The following is a description of a gene set: from publication Marigo I, Bosio E, Solito S, Mesa C, Fernandez A, Dolcetti L, Ugel S, Sonda N, Bicciato S, Falisi E, Calabrese F, Basso G, Zanovello P, Cozzi E, Mandruzzato S, Bronte V (PMID 20605485) Human Gene Set: GSE21927_BALBC_VS_C57BL6_MONOCYTE_SPLEEN_DN Tumor growth is associated with a profound alteration of myelopoiesis, leading to recruitment of immunosuppressive cells known as myeloid-derived suppressor cells (MDSCs). Analyzing the cytokines affecting myelo-monocytic differentiation produced by various experimental tumors, we found that GM-CSF, G-CSF, and IL-6 allowed a rapid generation of MDSCs from precursors present in mouse and human bone marrow (BM). BM-MDSCs induced by GM-CSF+IL-6 possessed the highest tolerogenic activity, as revealed by the ability to impair the priming of IFN- -producing CD8+ T cells upon in vivo adoptive transfer. Moreover, adoptive transfer of syngeneic, GM-CSF+IL-6-conditioned MDSCs to diabetic mice transplanted with allogeneic pancreatic islets resulted in long term acceptance of the allograft and correction of the diabetic status. Cytokines inducing MDSCs acted on a common molecular pathway. Immunoregulatory activity of both tumor-induced and BM-derived MDSCs was entirely dependent on C/EBP transcription factor, a key component of the emergency myelopoiesis triggered by stress and inflammation. Adoptive transfer of tumor antigen-specific CD8+ T lymphocytes resulted in therapy of established tumors only in mice lacking C/EBP in myeloid compartment. These data unveil another link between inflammation and cancer and identify a novel molecular target to control tumor-induced immune suppression. We used gene expression analysis to identify those factors, secreted by tumor-infiltrating MDSC, which could drive emathopoiesis. Moreover we compare gene expression profile of tumor-induced MDSC, obtained from either the spleen and the tumor infiltrate of tumor bearing mice, and in vitro bone marrow-derived MDSC. species: Homo sapiens Genes down-regulated in spleen CD11b cells: BALBc versus C57BL6 mouse strains., and this is the list of marker genes: ITPKB, NDUFAF1, SWSAP1 (NCBI Gene Id 126074), GARIN3, SLC25A45, VWDE, LACTB, DUS4L, IRAK2, ZNF407-AS1, ERCC5, LINC01554, LRRC2, LGI2, ZNF85, RTL8C (NCBI Gene Id 8933), LAMB2P1, KRT222, RTKN2, SLC24A5, GAPDHP62, AGPAT1, TPRG1, STX12, MESD, FAM169A, NQO2, DNAL4, SRGAP2, PXYLP1, PLXNA1, NUP37, CHI3L2, FKBP1B, F8, GALNT11, SLC40A1, CSNK1G1, ANKRD40, ZNF750, FAM220A, NFE4, TRBV27, BBS12, LYSMD3, SNX10, PRUNE1, LMAN1, NNMT, ANKRD36, XPNPEP3, TARS3, KRCC1, BLOC1S5, TTC27, YIPF5, BTBD8, CR1, LRRC14, SHBG, CCDC162P, SNHG12, GOLGA2P5, DOCK8-AS1, ARHGAP45, SLC35E1, DHX36, UMPS, ZNF786, ANKRD23, EPHA5, HIVEP2, HOXB8, LINC01792, NEK9, KRAS, AGK, DYNLT1, NEDD4L, C3orf36, UNG, PID1, KLF12, TCF20, SART3, LY86-AS1, USP44, UCN, PRRG2, NPR3, EIF2B2, CNOT9, ZNF837, DHX34, LINC00487, DPH3, TBX20, MIR7-3HG, TRMT10B, RBCK1, AFDN, ITGAV, TMEM106A, USP51, NDRG2, ZNF397, ATP6V0E1, TRBV24-1, WAPL, AIDA, AFG2A, PTCD1 (pentatricopeptide repeat domain 1), HTN3, FTX, ENSG00000268129, PDGFD, ANKRD7, PITPNA-AS1, AMIGO2, ASTE1, CCAR1, ZNF589, IFI16, METTL5, RAP1GDS1, MORC1, TNFRSF10B, RASA3, KRTAP9-9, CEP57L1, FCHO2, MAML2, LINC00926, BAG2, SCML1, PRKD3, NDUFC1, ANKRD20A11P, TRPC5OS, ZNF417, ATP11A-AS1, PIBF1, SLC25A43, CGN, CTSH, OR2S2, TIMM10, HGSNAT, ZNF251, SNRPF, LYRM9, JUN, NR3C2, SLAMF1, LINC03124, VNN3P, DYNC2H1, RAB3A, PRKAB2, IDH1, GSPT1, MYH8, GRM8, SHQ1, RPS26, CDC42SE1, NFKBIL1, TMEM192, RAB13, VCF2, DZIP1L, ZWILCH, GART, LRRC66, BBS4, MDGA2, RAB27A (RAB27A, member RAS oncogene family), FXYD7, TAX1BP3, BPIFB4, CTSV, NARS2, GCOM1, LGALSL, PIGB, ANKH, IL6, ZDHHC6, NFU1, TMEM132B